The following is a description of a gene set: Mouse Gene Set: GOBP_MEMBRANE_PROTEIN_PROTEOLYSIS species: Mus musculus The proteolytic cleavage of a transmembrane protein leading to the release of its intracellular or ecto-domains., and this is the list of marker genes: Sppl2a, Adam9, Aph1a, Ifng (interferon gamma), Sppl3, Il1b, Rbmx, Sh3d19, Psen2, Timp3, Sppl2c, Tspan15, Cwh43, Bace2, Lrig2, Tnf, Adam19, H13, App, Tgfb1, Aph1b, Tnfrsf1b, Mmp7, Adam8, Ctsh, Bace1, Mbtps1, Aph1c, Rgma, Pacsin3, Prkcq, Timp4, Snx33, Parl, Ptpn3 (protein tyrosine phosphatase, non-receptor type 3), Mbtps2, Erap1, Timp1, Timp2, Tspan17, Gpld1, Il10, Tspan5, Apoe, Psen1, Tmprss6, Adam10, Adam17, Sppl2b, Dag1, Napsa, Afg3l2, Adra2a, Nrdc, Prtn3, P2rx7, Ret, Psenen (presenilin enhancer gamma secretase subunit), Rhbdd1, Myh9 (NCBI Gene Id 97972), Rbmxl1, Snx9, Clpp, Ncstn